Given this list of marker genes GTF2E2, GTF2H5, DDB2, XPA, MPLKIP, TARS1, ERCC3, CARS1, ERCC5, ERCC6, RNF113A, AARS1, ERCC2, ERCC4, XPC, here is a description of the gene set: Defective DNA repair after ultraviolet radiation damage Human Gene Set: HP_DEFECTIVE_DNA_REPAIR_AFTER_ULTRAVIOLET_RADIATION_DAMAGE studied in species Homo sapiens